The following is a description of a gene set: Arteriosclerosis occurring at an age that is younger than usual. Human Gene Set: HP_PREMATURE_ARTERIOSCLEROSIS Premature arteriosclerosis studied in species Homo sapiens, and this is the list of marker genes: ABCG5, LDLR, PCSK9, APOB, ABCG8, LDLRAP1, WRN, LMNA